The following is a description of a gene set: Human Gene Set: GOBP_MICROAUTOPHAGY studied in species Homo sapiens A type of autophagy where cytosolic components are ingested by late endosomes, lysosomes or yeast-type lytic vacuoles by direct invagination of the compartment membrane without prior sequestration into an autophagosome. The engulfing membranes fuse, resulting in the lysosomal delivery of the cargo wrapped in a single membrane derived from the invaginated lysosomal membrane., and this is the list of marker genes: ATG4C, ATG2A, ATG7, RB1CC1, SNX7, VPS4A, ATG4A, ATG5, SNX30, ATG12, ULK3, ATG13, VPS4B, ATG4D, ATG16L1, ATG9A, ULK1 (NCBI Gene Id 8408), ULK2, ATG9B, ATG2B, ZNF418, ATG4B